The following is a description of a gene set: Genes predicted to be targets of miRBase v22 microRNA mmu_miR_135a_2_3p in miRDB v6.0 with MirTarget v4 prediction scores > 80 (high confidence targets). Mouse Gene Set: MIR_135A_2_3P from publication Chen Y, Wang X (PMID 31504780) studied in species Mus musculus, and this is the list of marker genes: G6pc2, Cert1, Btbd9, Dpysl5, Gm973, Inha, Vps35, Riox1, Dpysl2, Gfra2, Tmprss11f, Mroh6, Svip, Zfp729a, Sec31a, Ndufv2, Rabgap1l, Bmp5, Abcc4, Trib1, Slc39a12, P2ry13, Dcun1d1, Pde12, Il15ra, Map2k5, Ankrd33b, Igf2, Magi1, Zfand2b, Masp2, Optc, Gab3, Zfp175, Terb2, Dbt, Cyp4a31, Tcp10c, Gje1, Loxl2, Grk4, Hdac8, Rnf26, Chrm1, Synm, Tex9 (testis expressed gene 9), Zfp868, Spata3, Cep97, Tex56, Nuf2 (NUF2, NDC80 kinetochore complex component), Capns1, Ppp2r1a